Given this list of marker genes KDM3B, SMG8, DRC1, ADH5, DNAI1, OFD1, HYDIN, UBE2A, CIROP, LRRC56, CFAP74, DNAAF2, FANCB, DNAAF3, GAS2L2, ODAD2, SMAD2, DNAH11, MED25, ODAD3, TBX5, CWC27, DNAAF11, SLC29A3, CFAP221, DNAAF4, ZIC3, NME5, CLXN, NKX2-6 (NCBI Gene Id 137814), NCAPG2, SRCAP, ODAD4, DNAH9, SPAG1, PRKACB, ODAD1, SMOC1, RPGR, CFAP298, RSPH3 (NCBI Gene Id 83861), CREBBP, GNB2, TMEM260, ZNF699, PRKCD, MMP21, FOXJ1, SPEF2, DNAJB13, RAI1, MCIDAS, DNAAF6, ZMYND10, UQCRFS1 (ubiquinol-cytochrome c reductase, Rieske iron-sulfur polypeptide 1), CCDC39, ACVR2B, CCDC40, CFC1, FADD, EP300, STK36, ERCC8, TTC12, RBM10, DNAAF1, DNAH1, DNAI2, DNAH5, WT1, DNAL1, RSPH4A, MID1, BAP1, CCNO, CFAP300, RSPH9, NME8, FOXF1 (NCBI Gene Id 2294), DNAAF5 (dynein axonemal assembly factor 5), TBX1, PLXND1, RSPH1, ATN1, NEK10, LRPPRC (leucine rich pentatricopeptide repeat containing), here is a description of the gene set: Human Gene Set: HP_ABNORMAL_VENA_CAVA_MORPHOLOGY An abnormality of the structure of the veins that return deoxygenated blood from the body into the heart, i.e., the superior vena cava and the inferior vena cava. studied in species Homo sapiens Abnormal vena cava morphology